Given this list of marker genes PLB1, SULT1A2, GLIPR1, SULT1A4, VIPR1, here is a description of the gene set: Genes down-regulated in peripheral blood mononuclear cell 1d vs 0d in adults (18-64) (medium-high adverse events score) after exposure to Pandemrix, time point 1D studied in species Homo sapiens from publication Sobolev O, Binda E, O'Farrell S, Lorenc A, Pradines J, Huang Y, Duffner J, Schulz R, Cason J, Zambon M, Malim MH, Peakman M, Cope A, Capila I, Kaundinya GV, Hayday AC (PMID 26726811) Human Gene Set: SOBOLEV_PBMC_PANDEMRIX_AGE_18_64YO_MEDIUM_HIGH_ADVERSE_EVENTS_SCORE_1DY_DN Adjuvanted vaccines afford invaluable protection against disease, and the molecular and cellular changes they induce offer direct insight into human immunobiology. Here we show that within 24 h of receiving adjuvanted swine flu vaccine, healthy individuals made expansive, complex molecular and cellular responses that included overt lymphoid as well as myeloid contributions. Unexpectedly, this early response was subtly but significantly different in people older than ~35 years. Wide-ranging adverse clinical events can seriously confound vaccine adoption, but whether there are immunological correlates of these is unknown. Here we identify a molecular signature of adverse events that was commonly associated with an existing B cell phenotype. Thus immunophenotypic variation among healthy humans may be manifest in complex pathophysiological responses.